Given this list of marker genes KIF3B, RAPGEFL1, MOB4, F7, BCO2 (beta-carotene oxygenase 2), EIF4E2, CREB5, BLOC1S5, CFAP263 (cilia and flagella associated protein 263), FAM83G, POM121, C4orf19, ARID4A, ERBB3, MMD2, MEF2C, RCBTB2, PLCXD2, ADGRL3, GPX4, BAZ1A, TSPAN16, B4GALT1, SHOC2 (NCBI Gene Id 8036), TBC1D10A, PTPN4, AEBP2, SERF2 (NCBI Gene Id 88287), TIGD2, YY1, ERICH3, ZNF275, COX11, TAF5, KBTBD12, here is a description of the gene set: from publication Chen Y, Wang X (PMID 31504780) species: Homo sapiens Human Gene Set: MIR1909_5P Genes predicted to be targets of miRBase v22 microRNA hsa-miR-1909-5p in miRDB v6.0 with MirTarget v4 prediction scores > 80 (high confidence targets).